The following is a description of a gene set: studied in species Mus musculus Mouse Gene Set: REACTOME_TURBULENT_OSCILLATORY_DISTURBED_FLOW_SHEAR_STRESS_ACTIVATES_SIGNALING_BY_PIEZO1_AND_INTEGRINS_IN_ENDOTHELIAL_CELLS Turbulent (oscillatory, disturbed) flow shear stress activates signaling by PIEZO1 and integrins in endothelial cells, and this is the list of marker genes: Nfkbia, Abl1, Nfkb1, Ppp2r1b, Itgb1, Rela, Ptk2, Capn2, Chuk, Pde4d, Gna11, Fn1, Ikbkb, Yap1, Ppp2ca, Itga5, Capns1, Gnaq, Ikbkg, Vcl, Ptpn1 (NCBI Gene Id 19246), Ikbke, Ppp2r1a, Anxa2, Capns2, Itgb3, Ppp2r2a, Itgav